The following is a description of a gene set: species: Homo sapiens Human Gene Set: GOMF_UNIPORTER_ACTIVITY Catalysis of the transport of a single molecular species across a membrane; transport is independent of the movement of any other molecular species., and this is the list of marker genes: SLC17A9, MFSD1, SLC16A12, UCP2, SLC17A8, SLC17A7, SLC2A4, MCU, SLC17A6